The following is a description of a gene set: The presence of an embryonal neoplasm of the kidney that primarily affects children. studied in species Homo sapiens Embryonal renal neoplasm Human Gene Set: HP_EMBRYONAL_RENAL_NEOPLASM, and this is the list of marker genes: BUB1, BMPER, ALX4, HDAC4, C1S, SOX9, SETBP1, NR5A1, FIBP, REST, BUB1B, GATA4, TP53, SPRED1, CEP57, TRIM37, DHX37, WT1, VAMP7, BRCA2, POU6F2, MAP3K1, ZFPM2, WWOX, TRIM28, DIS3L2, GPC4, PIK3CA, IGF2 (insulin like growth factor 2), NR0B1, BUB3, BLM, TRIP13, KCNQ1OT1, KCNQ1, EXT2, PALB2, ASXL1, GPC3, SRY, PTCH1, HRAS, H19, CDC73, PAX6, PHF21A, DICER1, CDKN1C